Given this list of marker genes CADPS2, VTI1B, SYTL2 (NCBI Gene Id 84564), SYT7, EXOC6, BTK, OSBPL2, VAMP8, RPH3A, SNX4, CPLX1, SCRIB, RIMS1, RIMS2, RAB3A, UNC13B, SNCA, EXOC4, VPS18 (VPS18 core subunit of CORVET and HOPS complexes), EXOC7, SYT11, SYNJ1, SNX6, STX19, P2RX1, PLEK, SEPTIN5, KCNB1, SYNGR3, SNAP25, GNAO1, RABEPK, SYT1, VAMP7, STX2, VAMP3, SYT13, SYT8, STXBP3, SYT9, STXBP5, CFTR, NAPA, RAB8A, SYT2 (NCBI Gene Id 6858), VAMP2, FCER1G, CPLX3, GRIK5, RPH3AL, RIMS3, NAPB, BLOC1S6, CPLX2, EXOC5, RALB, DOC2A, TRARG1, STX1A, STXBP2, UNC13A, YKT6 (YKT6 v-SNARE homolog), SNPH, SYK, EXOC1, SNAP47, ERC2, SLC18A2, EXOC2, EXOC8, DOC2B, SV2A, BRSK1, SNAPIN, TPRG1L (NCBI Gene Id 127262), RAB44, STXBP1, SYP, PSEN1, PLA2G3, VPS11, SNAP29, CPLX4, STX11, SYT5, UNC13C, EXOC3 (exocyst complex component 3), NLGN1, PPFIA3, EXOC6B, STX1B, SYT4, PRRT2, EFR3A, SNAP23, LYN, here is a description of the gene set: Human Gene Set: GOBP_EXOCYTIC_PROCESS The cellular processes that contribute to exocytosis. studied in species Homo sapiens